Given this list of marker genes CDIN1, CXCL14, TENT2 (NCBI Gene Id 167153), SAMD14, EFEMP1, C3orf18, PLPPR1, NR2F6, SEC22B, PDLIM7, HOXD3, GLG1, RREB1, RTP3, F12, NR2F1 (nuclear receptor subfamily 2 group F member 1), ZBTB43, TREX1, PCBP4 (NCBI Gene Id 57060), FOXA3, RCC1L, ATAT1, NSUN5P2, OBSCN, RTN4, LRP1, ATP2B1, TCEA2, TTYH1, PRKAG1, SELENOI, TOM1L2, AP1B1, ID1, PRDM13, DMD, MARCKSL1, PNPLA2, ESRRA, NR2F2, PRDM16, HOXA3, AHCYL1, NKX6-3, CKS1B, MREG, CNTFR, DPF3, WTAP, SS18, TMEM79 (transmembrane protein 79), NUDCD1, CUTA (cutA divalent cation tolerance homolog), PAN2, ZSWIM3 (zinc finger SWIM-type containing 3), DCTN2, OVOL1, MRPS28, PAX7, YBX2, SCNM1, ACTA1, SMAD3, DIS3L, PALM, PRODH2, U2AF1L4 (NCBI Gene Id 8176), RNF5, LYSMD1, NYAP1, TAOK3, RNF144B, PDZK1, PTH1R, SLC26A6, ARFGEF2, SLC26A3, SZT2, BLTP3A, ZBTB40, DCTN1, TMEM259, LCAT, BCAM, CLSPN, WRAP53, APEX2, ZNF436-AS1, FOXA1, PRKCSH, SRSF4, NR2C1, ABTB2, ATN1, FXYD1, FBLN1, CSRNP3, SHC1, NRAP, BSDC1, CRABP2, ZNF485, IQCD, FGD2, HIBADH, NDUFS1, PSMF1, TRAF4, YPEL3, SLC23A3, FAM170A, ETFDH, KMT5A, EEF1B2, PIPOX, SLC16A9, CSF2, PRR7, GOLGA4, SMYD5, TP53, FABP1, CYP26A1, MAP2K3, UBE2R2, PHB2, LAMP2, POLR2H, NHERF4, NCDN, SEM1, CDK16, RNF139 (NCBI Gene Id 11236), SHFL, ARHGEF7, UQCR10, ATP5PO, CLDN15, STOML2, NSUN5P1, LONRF3, SLC39A5 (NCBI Gene Id 378941), RBBP6, ALPI, TTI1, MRPL11 (mitochondrial ribosomal protein L11), TPCN1, MTTP, ODAD3, HOXC13, INSR, PRDM1, PFN1, ARF6, ACOT8, GABARAPL2, KIRREL3, POU5F1, PRRX2, APOM, EMG1, PAX6, IRX6, SPACA6, TPM2, GBF1, PKP3, HMGCS2, PEX16, CELF3, HSD17B8 (NCBI Gene Id 7923), UBE2D3, ERBB2, ZIC4, TBC1D22A, ABI3BP, ACP4, PAK4, ENO3, KIF6, LMAN2L, TOMM70, TP53BP1, THPO, FAM131A, LMO3, ASXL1, PRKCD, BIN3, SALL1, C1orf116, PPP1R14D, RFX1, RPRD1B, HSPD1, SHISA5, CLCNKA, MLST8, REST, IFFO1, KCNE5, PPARGC1A, NPSR1-AS1, SAP18, ARL6IP1, ADAMTS19, DRC3, PRKACA, CBLN4, ZYX, ZFHX3, CLCN2, PNOC, TTR, HDAC11, HSPE1, SMG5, NR4A3, ARRDC1-AS1, VTA1, MYH10, KIRREL3-AS3, USP37, KCNK10, CNOT9, SYTL2, MED8, PAPLN, AGPAT1, NR4A1, MAP3K11, DNAJA2, BPIFA2, ZBTB12, KLK6, STMN2, ZNF768, AGPS, MICAL2, EIF4EBP2, EFNB3, SLC11A2, UBE2K, ADIPOQ, COMMD3, RBMS1, GDNF, ZNF436, SRSF6, SYMPK, RRBP1, CCDC71, PGF, ADGRA2, here is a description of the gene set: Human Gene Set: COUP_DR1_Q6 Genes having at least one occurrence of the motif TGACCTTTGACCC in the regions spanning 4 kb centered on their transcription starting sites. This matches the PITX2 transcription factor binding site V$COUP_DR1_Q6 (v7.4 TRANSFAC). species: Homo sapiens